Given this list of marker genes SPP1, CFB, C2, AKR1A1, TUT4, PLA2G4C, LARP1, SPINT2, FGL2, HLA-DQB1, ANOS1, TRIO, HLA-DMA, PDE6D, C1QB, DOP1B, BBC3, P4HA1, SDHA, FAM168A, DYNC2LI1, DOK1, ZNF451, CCND3, CD38, GIT2, VPS39, FKBP15, TNFSF12, ATOX1, ZNF593, POLR2A, ECHS1, XPO7, ACOX1, BTN3A3, BTN3A1, ZMYND8, SPHK2, DEAF1 (DEAF1 transcription factor), PLXNB2, STOM, IRAG2 (NCBI Gene Id 650574), CD1D, RABGGTA, PRKAR2B, MGAT1, LTA4H, LEPROTL1, ATP6V0A2, PEX14, MTCP1, TRANK1, RASGRP1, IFIT1, GLT8D1, GPX4, ZFP36L2, TCEAL1, ZFAND5, NDUFS2, ARAP1, OGT, TCOF1, TUBGCP2, SLC1A5, ARHGAP45, MTF1, SLC25A14, KAT8, MRE11, BCKDHA, TBC1D9, TRAPPC12, STAT1, DNASE2 (deoxyribonuclease 2, lysosomal), IKBKE, CLEC2B, GLG1, EDRF1, RFX5, PLAAT4, MYCL, FARSA, XPNPEP1, TMEM131L, PRCP, TBX19, PTGIR (NCBI Gene Id 5739), CYB5A, MSH2, RRAS, POLA2, ALAS1 (5'-aminolevulinate synthase 1), GSE1, OAZ2, NFE2L3 (NCBI Gene Id 9603), N4BP2L1, ZMIZ2, SERBP1, ATF6B, UCK2, ZDHHC18, PSMB10, MIF, IL27RA, TADA3, CEP57, RXRB, HHEX, TNFRSF14, ACAA1, PIK3CB (phosphatidylinositol-4,5-bisphosphate 3-kinase catalytic subunit beta), PTK2B, AIM2, PHF21A, CCR2, APOBEC3G, PDCD2, KCTD17, ATP6V0A1, NCAPD3 (non-SMC condensin II complex subunit D3), KIAA0513, OLFML2A, COG4, DDX11, ACP5, PSTPIP1, CSTF3, COG2, CTSC, NADK, ATIC, UVRAG, ZNF266, CDC40, CSK, WDR7, PSEN2, ZNF710, CHST2, KDM3B, GYPC, STAT5A, ZMYM3, DNPEP, CCDC85B, XPO6, MRTFA, HDAC5, PPL, PHB2, MRPL19, RGS3 (regulator of G protein signaling 3), DXO, SLC1A3, SKIC2, TSPYL5, PRKX, ARHGAP25, PLIN2, SLC20A1, HK2, ARHGEF2, MAPK14, VOPP1, SASH3, TGFBR2, PSMB9, ACP2, SMARCD3, STAT5B, APEX1, SLC6A12, EIF2S3, GSTO1, USP20, POLRMT, MYO1F, CA11, GNS, TP53, ADAM28, NR1H3, VPS13B, NEK4, SLC7A7, ABR, DTNB, HAX1, VEGFB (vascular endothelial growth factor B), DDX28, GGA2, GPD2, DDB2, RBBP4, ADH5, HLA-DMB, SCAMP3, FRAT2, here is a description of the gene set: Human Gene Set: GSE19401_NAIVE_VS_IMMUNIZED_MOUSE_PLN_FOLLICULAR_DC_DN Germinal centers (GCs) are clusters of activated B cells built on stromal cells known as follicular dendritic cells (FDCs). In the Peyer’s patches (PPs), GCs are chronically induced by bacteria and are the major sites for generation of gut IgA immune responses. Whether FDCs directly contribute to the IgA production in PP GCs is unknown. To investigate the role FDCs in gut immune system, we examined comprehensive gene profiles of FDCs purified from PPs or perypheral lymph nodes (pLNs) with or without immunization. We also tried to reconstitute the PP FDC signature in vitro by pulsed or continuous stimulation of pLN FDCs through TLRs, RARs or simultaneously through TLRs and RARs. studied in species Homo sapiens from publication Suzuki K, Maruya M, Kawamoto S, Sitnik K, Kitamura H, Agace WW, Fagarasan S (PMID 20643338) Genes down-regulated in ex vivo follicular dendritic cells from peripheral lymph nodes: naïve versus immunized mice.